The following is a description of a gene set: studied in species Mus musculus The binding of a peptide to the antigen binding groove of an MHC protein complex. Mouse Gene Set: GOBP_PEPTIDE_ANTIGEN_ASSEMBLY_WITH_MHC_PROTEIN_COMPLEX, and this is the list of marker genes: Pdia3, H2-Eb2, H2-Ea, H2-Aa, H2-Ob, H2-DMa, Tapbpl (TAP binding protein-like), H2-Oa, H2-Eb1, H2-Ab1, B2m, H2-DMb2, H2-DMb1, Tapbp, Calr